Given this list of marker genes ATRX, DAXX, here is a description of the gene set: Reactome Pathway: Defective Inhibition of DNA Recombination at Telomere ATRX (Alpha thalassemia mental retardation X-lined) and DAXX (Death domain-associated protein 6) chromatin remodeling factors form a complex that binds to subtelomeric regions and plays a role in inhibition of DNA recombination at telomere ends, probably by mediating loading of H3F3A histone at telomere ends and by repressing transcription of TERRA (Telomeric repeat containing RNA), a long noncoding telomeric repeats-containing RNA. Tumors positive for alternative lengthening of telomeres (ALT) markers often harbor loss-of-function mutations in ATRX, and more rarely in DAXX or missense mutations in H3F3A, implying that the impairment of function of one of these three proteins may contribute to initiation of the ALT process. Additionally, mutations in IDH, the tumor suppressor TP53 and SMARCAL1 are also observed in the context of ALT in certain types of human cancers, particularly sarcomas and tumors of the central nervous system. For review, please refer to Gocha et al. 2013, Pickett and Reddel 2015, Amorim et al. 2016). part of: Alternative Lengthening of Telomeres (ALT) species: Homo sapiens